The following is a description of a gene set: A collection of pus in the area of the rectum. Human Gene Set: HP_RECTAL_ABSCESS Rectal abscess species: Homo sapiens, and this is the list of marker genes: TTC7A, ITGB2, NCF2, CYBA, IGHM, VANGL1, CYBB, PI4KA, NCF1, RAC2